Given this list of marker genes FAM3C, MAP3K9, LBH, SYBU, DNMT1, PMVK, ING1, DUSP14, PERP, UTP18, RPS4X, CNPY2, AGPAT5, PLCH2, RUFY1, CCHCR1, RPL37, ACTL6A, SERPINB9, TMEM268, PSME1, DNAJC16, UTP3, TCL1A, RPS21, RERE, SCRN1, COX7A2L (cytochrome c oxidase subunit 7A2 like), MCUR1, OSBPL3, ATP5F1C, SLC38A10, AKR1B1, OR7E47P, FTO, IGHV5-78, ZNF473, EIF2S1 (eukaryotic translation initiation factor 2 subunit alpha), FANCG, VILL, MRPS30, RPL4, FBL, CTNNA1, PWP1, PRPSAP2, KPNA2, PGRMC2, MCM3, TRAF3IP2, MAT2B, ABCF2, ZNF444, BLMH, RUBCN, CSH2, UMPS, RRN3, RRM1, HOPX, CAD, PEPD, MANF, NIPSNAP1, DHFR, TRIT1, RRS1, KLHDC4, CTNNA2, MAP2K6, AGK, CD72, MRPS33 (NCBI Gene Id 65515), ATP6V1G1, NAA40, HLA-DRB6, TOP2A, SHMT2, LAT2, FN3KRP, CASP7, SAMM50, ASNS, MAPKBP1 (mitogen-activated protein kinase binding protein 1), GOLGA3, E2F8, IGLL3P, HLA-DPA1, BAZ1B, DUSP7, CLIC4, LAX1, IL15RA, USP10 (NCBI Gene Id 9100), NDUFAB1, MTX1, FAT2, EEF1G, GLDC, DPAGT1, PCBP3, STOML2, NUP133, KDM1A, NVL, IFI16, CRIP1, PMS2P1, DNAJC15, JMJD4, RPS6, TMEM70, SREBF2, GATB, FDX1, ETFB, APOLD1, PARN, ZNF32, CBX5, B3GNT2, SKIC8, FHL1, RPL7A, PPM1E, PNP, ZDHHC14, MYBBP1A (NCBI Gene Id 10514), FHIP2B, DAP3, ATP5IF1, IGKC (NCBI Gene Id 3514), NDUFB2, TCF3, NGDN, TBC1D5, CTCF, KDM7A, BHLHE41, PFAS, PRMT5, DHX58, REEP5, IGHM, IL27RA, ZNHIT2, JADE2, RPL7 (ribosomal protein L7), MPV17, AUTS2, FOXK2, MAB21L1, INSL3, RPS16, SMARCA4, AKR7A2 (NCBI Gene Id 94395), LARS2, CAPN2, MRPL35, RXYLT1, NUP205, RABGAP1, CCNE1, PEX19, ANXA2P2, IRF4, DUSP22, HLA-DOB, SUCLG2, ABCD4, SPINK2, WDR11 (NCBI Gene Id 79207), PRRC2B, MTSS1, RPS5, GBA1LP, HTRA2, AP3D1, NT5E, TCFL5, NDUFA8, RACGAP1, GORASP2 (golgi reassembly stacking protein 2), KCNH4, DNMBP, DHX57, MZB1, EIF3M, ACAD10, PHKB, MMS19, ATRN, KCNA3, SLC35E2B, PRKRA, RUBCNL, NDUFA7, TRADD, here is a description of the gene set: In the present study we used Affymetrix oligonucleotide microarrays to produce gene transcription profiles for the major leukocyte types in humans. This comprehensive dataset enabled us to not only establish which genes were expressed in each leukocyte type, but also which genes were expressed in each subset after activation. The used of a comprehensive dataset of gene profiles from all the major human leukocyte subsets enabled a novel and powerful means for identification of genes associated with single leukocyte subsets, or different immune paradigms. Genes down-regulated in comparison of eosinophils versus B cells. from publication Jeffrey KL, Brummer T, Rolph MS, Liu SM, Callejas NA, Grumont RJ, Gillieron C, Mackay F, Grey S, Camps M, Rommel C, Gerondakis SD, Mackay CR (PMID 16474395) species: Homo sapiens Human Gene Set: GSE3982_EOSINOPHIL_VS_BCELL_DN